Given this list of marker genes FRMD3, LPL, KCNJ8 (potassium inwardly rectifying channel subfamily J member 8), ITM2C, AGTR1, MARCKSL1, OAZ2, IFI27, CCND1, TXNIP, IMPA2, PLAT, SLC12A2, COX4I2, COL4A1, RASD1, EDNRB, GUCY1A2, HIGD1B, FABP4, ISG15, MYO1B, PAG1 (phosphoprotein membrane anchor with glycosphingolipid microdomains 1), NID1, CYBA, TFPI, COL6A3, THY1, CYGB, ARHGDIB, FABP5, ITGA1, FAM162B, IFI6, COL3A1, FXYD6, SEPTIN4, ADISSP, GMFG, ASAH1, CCDC102B (NCBI Gene Id 96), COL4A2, SEPTIN11, PLXDC1, CCND2, STEAP4, APOLD1, PRXL2A, KCNE4, CD36, here is a description of the gene set: In this study, an extensive analysis was conducted to define meta-programs (MPs) capturing intra-tumor heterogeneity across a spectrum of tumor types. The approach utilized non-negative matrix factorization (NMF) to analyze each cell type separately within individual tumor samples. This involved the analysis of malignant cells, macrophages, fibroblasts, endothelial cells, epithelial cells, T-cells, and B-cells. NMF was executed with varying parameter values (K=4, 5, 6, 7, 8, 9), thereby generating 39 programs for each cell type per sample. Each NMF program was summarized by the top genes based on NMF coefficients.\nRobust MPs were then delineated for each cell type using a set of stringent criteria, including recurrence within the same tumor, similarity to programs in other tumors, and non-redundancy within a tumor. Subsequently, these robust NMF programs were clustered (per cell type) based on Jaccard similarity, leading to the identification of MPs associated with each cell type.\nTo enhance the quality of the MPs, a refinement steps were undertaken, involving the removal of MPs suspected of reflecting low-quality data (with an overrepresentation of ribosomal proteins or mitochondrial-encoded genes), single-study inclusion, or similarity to miss-annotated cell types. from publication Gavish A, Tyler M, Greenwald AC, Hoefflin R, Simkin D, Tschernichovsky R, Galili Darnell N, Somech E, Barbolin C, Antman T, Kovarsky D, Barrett T, Gonzalez Castro LN, Halder D, Chanoch-Myers R, Laffy J, Mints M, Wider A, Tal R, Spitzer A, Hara T, Raitses-Gurevich M, Stossel C, Golan T, Tirosh A, Suvà ML, Puram SV, Tirosh I (PMID 37258682) Human Gene Set: GAVISH_3CA_METAPROGRAM_FIBROBLASTS_LIPID_METABOLISM studied in species Homo sapiens Genes upregulated in subsets of cells of a given type within various tumors